Given this list of marker genes MRPL22, NEMP2, ATP5MC3, HNRNPUL1, SLC1A2, C12orf71, CTPS1, ADGRG2, SYDE1, SAMD4B, LRFN1, SIGLEC8, FLYWCH1, RIGI, FAM13A, BCAM, ZNF81, CACNA2D2, ELAVL3, PIK3CA, ACVR2A, MEX3D, KPNA5, B4GALT5 (beta-1,4-galactosyltransferase 5), SHC1, GALNT11, PLEKHB1, CIDEB, KLHL28, HOXA3, ADGRL2, CPPED1, CREB3L2, CABP5, NIPAL4, DISC1, HTR1B, HLA-DOB, RAX2, GIT1, SEMA5A, MTCL2 (NCBI Gene Id 90072), CD37, ARID4A, SPTY2D1, GOLT1A, SCUBE2, SLC39A13, CTBP2, MAML1, WDR89, APPBP2, ZNF229, CELF6, DUSP3, SLC25A23, MMRN2, MB21D2, ZNF74, NHSL1, ADAM23, FKBP7, EN2, GPX5, SINHCAF, CDK9 (cyclin dependent kinase 9), FHIT (fragile histidine triad diadenosine triphosphatase), WDR73, GYPE, KCNJ8, BTRC, RPS6KA6, CLIP3, SRP68, ST3GAL2, here is a description of the gene set: studied in species Homo sapiens from publication Chen Y, Wang X (PMID 31504780) Human Gene Set: MIR4450 Genes predicted to be targets of miRBase v22 microRNA hsa-miR-4450 in miRDB v6.0 with MirTarget v4 prediction scores > 80 (high confidence targets).